The following is a description of a gene set: species: Homo sapiens Human Gene Set: GOBP_ESTABLISHMENT_OF_TISSUE_POLARITY Coordinated organization of groups of cells in a tissue, such that they all orient to similar coordinates., and this is the list of marker genes: FZD3, ERBB4, DLG3, FOXF2, WDR1, GRHL3, SAPCD2, JHY, CELSR1, SEC24B, IFT20, SFRP2, FZD6 (frizzled class receptor 6), TTC8, PKHD1, ASTN2, WNT5A, PTK7, SFRP1 (NCBI Gene Id 6422), EXOC5, CTHRC1, RPGRIP1L, VANGL2, INTU, BRSK2, FUZ, WNT9B (Wnt family member 9B), WDPCP, PAFAH1B1, NPHP1, BRSK1, TP63